Given this list of marker genes Dgat2, Dgat2l6, Pnpla3, Awat2, here is a description of the gene set: electronically inferred by orthology from the curated human pathway Reactome Pathway: Acyl chain remodeling of DAG and TAG part of: Glycerophospholipid biosynthesis This event has been computationally inferred from an event that has been demonstrated in another species.<p>The inference is based on the homology mapping from PANTHER. Briefly, reactions for which all involved PhysicalEntities (in input, output and catalyst) have a mapped orthologue/paralogue (for complexes at least 75% of components must have a mapping) are inferred to the other species. studied in species Mus musculus